The following is a description of a gene set: part of: FGFR1 ligand binding and activation species: Homo sapiens Reactome Pathway: FGFR1b ligand binding and activation This pathway depicts the binding of an experimentally-verified range of ligands to FGFR1b. While binding affinities may vary considerably within this set, the ligands listed have been established to bring about receptor activation at their reported physiological concentrations., and this is the list of marker genes: GIPC1, FGF1, FGF2, TGFBR3, FGF10, FGF22, FGF3 (fibroblast growth factor 3), FGFR1